Given this list of marker genes Tbcc, Cryaa, Tbca, Cryab, Tbcd, Tbcel, Tbcb, Wdr72, Vbp1, Tbce, here is a description of the gene set: species: Mus musculus The aggregation and bonding together of alpha- and beta-tubulin to form a tubulin heterodimer. Mouse Gene Set: GOBP_TUBULIN_COMPLEX_ASSEMBLY